The following is a description of a gene set: Reactome Pathway: Transport of the SLBP Dependant Mature mRNA Transport of U7 snRNP and stem-loop binding protein (SLBP) processed mRNA. part of: Transport of Mature mRNAs Derived from Intronless Transcripts species: Homo sapiens, and this is the list of marker genes: SEC13, NUP62 (nucleoporin 62), NUP188, NUP42, NUP133, POM121C, NCBP1, NUP88, EIF4E, RAE1, AAAS, NUP153, NUP93, POM121, NXF1, RANBP2, TPR, NDC1 (NDC1 transmembrane nucleoporin), NUP37, NUP205, NUP50, NUP85, SLBP, NUP43, NUP214, NCBP2, NUP107, NUP160 (NCBI Gene Id 80116), NUP35, NUP54, NUP210, NUP155 (nucleoporin 155), ALYREF, NUP58, SEH1L, NUP98